Given this list of marker genes HIPK2, ZFYVE19, FCRL1 (NCBI Gene Id 115350), RENBP, SLC37A4, KATNB1, SRGN, HIP1, GPR137B, CPOX, SUSD3, ALDOC, CPD, DYNLL1, LPCAT1, IL1RL1, RBPJ, SERINC3, B4GALNT4, FRMD5, GVINP1, GATM, NR4A2, PLS3, KLRG1, BSPRY, HADH, SBF2, FARP1, S100A13, GRINA, IL1R2, PPARG, VIM, S100A6, PLIN2, CCR2, TNFRSF1B, NEB, SLC25A14, EHD4, LGALS1, APRT, F2RL1, PREX1, SH3BGRL, RTL5, COBLL1, PLSCR1, MAGED1, TNFSF10, CD101, LGALS3, TENT5A, PLXDC1, TNFRSF13B, CXCR4, ODC1, DST, FGF16, CHIC1, FUCA2, TTC39C, HACD3, CRTC3, ANXA6, IRF5, ID2, KLF8, STX11, CORO2A, PSEN2, HRAS, LGMN, TMEM154, S100A11, IL7R, ZCCHC18, PENK, PRNP, USP11, KATNAL1, AHR, MID2, CHST12, CLDND1, FLNB, H1-5, ITPR1, TBC1D25, OSBPL3, ATP6V0D2, FAM120C, GMFG, CCR8, TIGIT, PCTP, SYTL1, SLC52A1, RBL2, SNTB1, RAB27A (RAB27A, member RAS oncogene family), VPS54 (NCBI Gene Id 51542), GPR68, NPC1, RPS4Y2, ACOT7, CEP112, RGS16, RACGAP1, H2AZ1, ERBB3, S100A4, NBEAL2, RORA, LPAR6, GATA3, CCR1, SRXN1, GPR15, IGFBP7, XIST, RLN3, TRAF3IP2, MYO1F (myosin IF), HIP1R, ZC3H18, LMNB1, MDH1, CD44, CD74, CRIP1, CXCR6, KIF1B, ZMIZ1, RARA, NPNT, PEAR1, MLKL, ADAM19, EIF2AK2, LAMC1, ARL5A, ADAP1 (ArfGAP with dual PH domains 1), GBP6, CAPG, AXL, LYN, CD200R1, GZMB, ITGAE, PCYT1B, RUNX2, S100A10, GOLM1, NIBAN1, NIBAN2, SMOX, CASP1, CHD7, TAX1BP3, EML2, GM2A, PRR13, KCTD9, LY6S, IDI2, TMBIM1, CRMP1, PNKD, PRR11, ATP2B4, DNAJB13, FGL2, CCR3, H1-0, LGALS3BP, ICOS, here is a description of the gene set: from publication Chessler AD, Unnikrishnan M, Bei AK, Daily JP, Burleigh BA (PMID 19201883) Genes down-regulated in skin: wildtype (BALB/c) versus IFNAR1 knockout. species: Homo sapiens To investigate the early host response triggered by three different strains of Trypanosoma cruzi at a local infection site, changes in host gene expression were monitored in a murine intradermal infection model using Affymetrix oligonucleotide arrays. Robust induction of IFN-stimulated genes (ISGs) was observed in excised skin 24 hours post-infection where the level of ISG induction was parasite strain-dependent with the least virulent strain triggering a muted IFN response. Infection of mice immunodepleted of IFNγ-producing cells or infection of IFNγ-deficient mice had minimal impact on the IFN response generated in T. cruzi infected mice. In contrast, infection of mice lacking the type I IFN receptor demonstrated that type I IFNs are largely responsible for the IFN response generated at the site of infection. These data highlight type I IFNs as important components of the innate immune response to T. cruzi the site of inoculation and their role in shaping the early transcriptional response to this pathogen. We used microarrays to detail the local host transcriptional response to intradermal T. cruzi infection in WT mice and mice depleted of NK cells, or deficient in IFN-gamma or type I IFN responses. Additionally we compared the local host-transcriptional response generated to infection with 3 different strains of Trypanosoma cruzi (Y, Brazil, and G). Human Gene Set: GSE13522_WT_VS_IFNAR_KO_SKIN_DN